Given this list of marker genes KANSL1, KCNH1, FBN2, EIF4H (NCBI Gene Id 94573), HNRNPK, STX1A, ZMPSTE24, TMEM270, BGN, LMNA, COL1A2, VPS37D, PDPN, COL5A1, ZFX, PKD1, GJA5, ABL1, PPP1CB, PGM3, THBS2, ATP6V1A, COL3A1, SPEN, FLNA, BAZ1B, FBLN5, METTL27, NCF1, SKI, SLC2A10, THSD4, ALDH1A2, IFT140 (intraflagellar transport 140), TPM2, CHST3, TGFBR1 (NCBI Gene Id 7046), FMR1, GTF2I, ELN, HSPG2, SMAD2, NPR3, TBL2, MYPN, SMAD4, GTF2IRD1, PRKCZ, PIGN, BICC1, ERCC8, RAP1B, GABRD (NCBI Gene Id 2563), CHD7, SPECC1L, LYN, SMAD3, ATP6V1E1, IL12B, TGFB3, MFAP5, GJA8, LOX, ADAMTS19, ROBO4, COL1A1, SMAD6, FKBP6, NOTCH1, ERCC6, ENG, LIMK1, GTF2IRD2, B3GAT3, UBE4B, TGFBR3, IPO8, MID1, TGFB2, MED12, PRKG1, EFEMP2, GATA5, LUZP1, MMP23B, ALG9, ACTA2, CASZ1, THSD1, AEBP1, ALG5, TPM3, GANAB, DNAJC30, FOXE3, DNAJB11, HEY2, BRF1, SEMA3E, COL5A2, TGFBR2, NODAL, KCNAB2, HLA-B, FBN1, DNMT3A, RFC2, MYH11, PKD2, PRDM16, CLIP2, BUD23, NKX2-5, NKAP, RERE, MYLK, MAT2A, ANGPTL6, MLX, CARS1, ATP2B1, AFF4, B3GALT6, here is a description of the gene set: Thoracic aortic aneurysm Human Gene Set: HP_THORACIC_AORTIC_ANEURYSM studied in species Homo sapiens An abnormal localized widening (dilatation) of the thoracic aorta.